The following is a description of a gene set: species: Mus musculus Mouse Gene Set: GOBP_ANTIGEN_PROCESSING_AND_PRESENTATION_OF_PEPTIDE_ANTIGEN_VIA_MHC_CLASS_I The process in which an antigen-presenting cell expresses a peptide antigen on its cell surface in association with an MHC class I protein complex. Class I here refers to classical class I molecules., and this is the list of marker genes: H2-T3, Raet1e, H2-D1, Azgp1, Bag6, Hfe, Lgmn, H2-Q2, Fcgr1, H2-M5, H2-Q6, Mpeg1 (macrophage expressed gene 1), H2-M10.3, H2-T13, Clec4a3, H2-Q10, H2-Q7, H2-M2, H60c, H2-T23, B2m (beta-2 microglobulin), H2-Q4, H2-M11, H2-T22, H2-T24, Ifi30, Ide, H2-T5, Mr1, H2-M10.5, Tap2, Tapbpl, Ulbp1, H2-M3, H2-M10.1, Calr, Fcgr3, Pdia3, Tap1, H2-M10.6, H2-M1, Clec4a4, H2-K1, H2-M10.4, H2-T15, H60b, Fcer1g, H2-Q1, Clec4a2, H2-M10.2, Raet1d, 2410137M14Rik, Mfsd6, Tapbp (NCBI Gene Id 28066), H2-M9